Given this list of marker genes CCDC66, CCDC63, TTLL3, RSPH3, AK8, CFAP210, DYNLT4, DNAH11, SPMIP11, SPMIP9 (NCBI Gene Id 200523), DNAH3, CENPF, DNAH10, SPMIP6, PIERCE2, BBS5, SAXO4, IFT70B, WDR11, DNAH9, TEKT2 (tektin 2), CFAP70, BBS7, RP1, CFAP184, DNAI7, PACRG, SEPTIN7, TUBB4A, ROPN1L, DNAAF1, ODAD2, SPAG16, IFT140, CFAP263, CCDC65, LCA5L, BRWD1, CFAP206, RP1L1 (RP1 like 1), NME8, DRC1, ARFGEF2, PRKAR1A, TEKT3, CFAP251, TUBA1A, PIK3C3, TEKT4, DYNC2I2, SPEF1, CFAP68, CTSH, DUSP21, CCDC40, ODAD1, GABARAP, DNAJB13, CFAP95, LCA5, PRKACA, BBOF1, CFAP61, SEPTIN9, ARL13B, RPGRIP1, CAMSAP3, CFAP221, CFAP119, RIBC2, SPATA7, SPACA9, CFAP91, EFHB, CCDC39, CIMIP2C, TSSK6, GAS8, SSNA1, EFHC2, DYDC1, RIBC1, DNAH7, SPMIP8, SPAG17, CFAP74, TULP3, TRAF3IP1, MNS1, DZIP1L, TOGARAM1, CFAP126, WDR35, WDPCP (NCBI Gene Id 51057), RSPH6A, CFAP54, CFAP36, DNAI4, RSPH1, TTLL8, GLI1, DNAH2, SAXO1, CCSAP, RSPH9, MAK, SAXO2, DNAI3, CFAP73, CFAP107, DNAH1, CFAP276, CFAP141, CIMIP2A, TEKT1, ATG5, DNAH5, EFCAB6, IQUB (IQ motif and ubiquitin domain containing), GNAT3, IFT70A, ENKUR, RSPH14, IFT57, ODAD4 (outer dynein arm docking complex subunit 4), RPGRIP1L, AMBRA1, TEKTIP1, BBS1, TUBB4B, CCDC146, MAP4, GLI3, RSPH4A, DNAH17, CFAP161, EFHC1, MAPK15, SEPTIN2, AKAP14, IFT172, DNHD1, DNAI1, DYNC2LI1, ODAD3, ARL6, CFAP20, CIMIP2B, DNAH6, CFAP100, DNAI2, CFAP77, SPAG6, PIK3R4, DYNC2H1, NME7, DNAH12, DNALI1, ATG16L1, CCDC103, CFAP43 (NCBI Gene Id 80217), TEKTL1, KIF17, KIF19, MAP1LC3B, SPAG8, DNAH8, CFAP144, PRKAR2A, DCDC2 (NCBI Gene Id 606719), PIERCE1, CFAP45, KIFAP3, TEKT5, HYDIN, INPP5E, CEP162, NME5, CFAP52, NEK4, SPATA4 (NCBI Gene Id 170560), DRC3, CFAP46, ATG7, CFAP53, ATG14, CFAP90, DYNLT2B, DNAL1 (NCBI Gene Id 83544), SPMIP10, here is a description of the gene set: studied in species Homo sapiens Human Gene Set: GOCC_CILIARY_PLASM All of the contents of a cilium, excluding the plasma membrane surrounding the cilium.